The following is a description of a gene set: part of: Generic Transcription Pathway; Signaling by TGF-beta Receptor Complex Reactome Pathway: Transcriptional activity of SMAD2/SMAD3:SMAD4 heterotrimer species: Homo sapiens In the nucleus, SMAD2/3:SMAD4 heterotrimer complex acts as a transcriptional regulator. The activity of SMAD2/3 complex is regulated both positively and negatively by association with other transcription factors. In addition, the activity of SMAD2/3:SMAD4 complex can be inhibited by nuclear protein phosphatases and ubiquitin ligases., and this is the list of marker genes: PARP1, UBB, UBE2D3, TGIF2, SMAD4, SP1, NCOR2, TFDP2, RBL1, UBA52, YBX1, SMAD7 (NCBI Gene Id 4092), EP300, TFDP1, CDK8, CCNT2, SMURF2, FURIN, NEDD4L, MEN1, USP9X, MAPK3, TGIF1, CCNC (NCBI Gene Id 892), SERPINE1, E2F5, NCOR1, ATP1B4, CCNT1, UBC, MAPK1, E2F4, TRIM33, COL1A2, RPS27A, SNW1, CCNK, JUNB, HDAC1, WWTR1, PPM1A, MYC, STAT1, CDK9, CDKN2B, RNF111, SMAD3, SKIL, SKI, SMAD2, UBE2D1